Given this list of marker genes FBXW11, PABPN1L, FBXW7, FBXW5, FBXL2, FBXO9, FBXO46, FBXO6, CUL5, FBXL5, FBXL16, FBXO27, CUL1, RBX1, FBXL18, CCNF, FBXO4, FBXW4, SKP1, FBXL15, NCCRP1, FBXO31, FBXO48, FBXL17, BTRC, FBXL7, STYX, DMAC2, KIF14, FBXL14 (NCBI Gene Id 144699), FBXO38, FBXL6, FBXO39, FBXL4, FBXO3, SKP2, FBXO44, FBXL13, AMN1, FBXO2, CUL2, FBXO17, FBXL3, WWTR1, FBXL20, here is a description of the gene set: species: Homo sapiens Human Gene Set: GOBP_SCF_DEPENDENT_PROTEASOMAL_UBIQUITIN_DEPENDENT_PROTEIN_CATABOLIC_PROCESS The chemical reactions and pathways resulting in the breakdown of a protein or peptide by hydrolysis of its peptide bonds, initiated by the covalent attachment of ubiquitin, with ubiquitin-protein ligation catalyzed by an SCF (Skp1/Cul1/F-box protein) complex, and mediated by the proteasome.